The following is a description of a gene set: Mouse Gene Set: GOBP_REGULATION_OF_GASTRO_INTESTINAL_SYSTEM_SMOOTH_MUSCLE_CONTRACTION species: Mus musculus Any process that modulates the frequency, rate or extent of gastro-intestinal system smooth muscle contraction., and this is the list of marker genes: Nmu, Ptafr, Ptger3, Ghsr, Ptger4, Kcnma1, Kit, Ghrl, Spx